Given this list of marker genes ADK, NUDT18, SAMHD1, DNPH1, NUDT16, DCK, ADA, NT5C, NT5C2, NUDT15, PNP, XDH, NT5C1A, GUK1, DGUOK, AK5, GDA, here is a description of the gene set: The chemical reactions and pathways involving purine deoxyribonucleotide, a compound consisting of deoxyribonucleoside (a purine base linked to a deoxyribose sugar) esterified with a phosphate group at either the 3' or 5'-hydroxyl group of the sugar. studied in species Homo sapiens Human Gene Set: GOBP_PURINE_DEOXYRIBONUCLEOTIDE_METABOLIC_PROCESS